The following is a description of a gene set: Mouse Gene Set: GOBP_GENOMIC_IMPRINTING studied in species Mus musculus The establishment of epigenetic modifications (imprints) during gametogenesis, and propagation of these imprints during the organism's life. Genomic imprinting leads to an asymmetry between the maternal and paternal alleles and differential expression of the corresponding alleles. This can happen through heterochromatin formation or differential chromatin loop formation., and this is the list of marker genes: Dnmt3a, Ndn, Prmt7, Mta2 (NCBI Gene Id 23942), Gnasas1, Dnmt3l, Kcnq1ot1, Kdm1b, Eed (NCBI Gene Id 16759), Arid4b, Zdbf2, Zfp42, Smchd1 (SMC hinge domain containing 1), Ctcf, Dnmt3b, Gsk3a, H19, Airn, Gsk3b, Pik3ca, Xist, Tsix, Meg3, Mycn, Ctcfl, Arid4a, Mecp2, Trim28, Zfp57, Prdm14, Gnas, Cdkn1c